Given this list of marker genes Gpaa1, Pigs, Pigu, Pigk, Pigt, here is a description of the gene set: A transamidation reaction that results in the cleavage of the polypeptide chain and the concomitant transfer of the GPI anchor to the newly formed carboxy-terminal amino acid of the anchored protein. The cleaved C-terminal contains the C-terminal GPI signal sequence of the newly synthesized polypeptide chain. Mouse Gene Set: GOBP_ATTACHMENT_OF_GPI_ANCHOR_TO_PROTEIN species: Mus musculus